Given this list of marker genes TAF12, ATXN7, TAF10, TADA3, TAF9, KAT2A, SAP130, TAF6L, TAF5L (NCBI Gene Id 27097), SUPT3H, TRRAP, TADA1, SUPT7L, here is a description of the gene set: Human Gene Set: NAGY_STAGA_COMPONENTS_HUMAN from publication Nagy Z, Tora L (PMID 17694077) Composition of the 2 MDa human STAGA complex containing KAT2A. studied in species Homo sapiens Transcription in eukaryotes is a tightly regulated, multistep process. Gene-specific transcriptional activators, several different co-activators and general transcription factors are necessary to access specific loci to allow precise initiation of RNA polymerase II transcription. As the dense chromatin folding of the genome does not allow the access of these sites by the huge multiprotein transcription machinery, remodelling is required to loosen up the chromatin structure for successful transcription initiation. In the present review, we summarize the recent evolution of our understanding of the function of two histone acetyl transferases (ATs) from metazoan organisms: GCN5 and PCAF. Their overall structure and the multiprotein complexes in which they are carrying out their activities are discussed. Metazoan GCN5 and PCAF are subunits of at least two types of multiprotein complexes, one having a molecular weight of 2 MDa (SPT3-TAF9-GCN5 acetyl transferase/TATA binding protein (TBP)-free-TAF complex/PCAF complexes) and a second type with about a size of 700 kDa (ATAC complex). These complexes possess global histone acetylation activity and locus-specific co-activator functions together with AT activity on non-histone substrates. Thus, their biological functions cover a wide range of tasks and render them indispensable for the normal function of cells. That deregulation of the global and/or specific AT activities of these complexes leads to the cancerous transformation of the cells highlights their importance in cellular processes. The possible effects of GCN5 and PCAF in tumorigenesis are also discussed.